Given this list of marker genes AGBL3, AGBL1, AGTPBP1, AGBL4, AGBL5, AGBL2, here is a description of the gene set: Human Gene Set: GOBP_PROTEIN_SIDE_CHAIN_DEGLUTAMYLATION species: Homo sapiens The removal of a glutamate residue from the side chain of a protein. Glutamate side chains are added to glutamic acid residues within the primary protein sequence during polyglutamylation.